The following is a description of a gene set: species: Homo sapiens Human Gene Set: HP_GONADOBLASTOMA Gonadoblastoma The presence of a gonadoblastoma, a neoplasm of a gonad that consists of aggregates of germ cells and sex cord elements., and this is the list of marker genes: WWOX, SRY, ZFPM2, GATA4, IGF2, KCNQ1, PAX6, DHX37, KCNQ1OT1 (NCBI Gene Id 11111), DHH, WT1, CDKN1C, MAP3K1 (NCBI Gene Id 4214), NR0B1, NR5A1, VAMP7, SOX9